Given this list of marker genes AFF1, DKK1, SNHG7, SLC16A1-AS1, ARL6IP1, TUBB4B, CALR, H3C12, SNORD50B, H2AC10P, RPS12, LDHA, IER3, MYL6, SLC3A2, LGALS1, H2BC7, VASN, PTMA, ID2-AS1, CLASP1 (NCBI Gene Id 23332, cytoplasmic linker associated protein 1), HNRNPA2B1, SLC20A1-DT, CITED2, ID4, SLC16A1, ARL15, THBS1, GEMIN6, SNHG3, STMN1, H2AC20, SNORD60, SNORA78, TOB2, KHDC4, SNHG29, MIR222HG, EEF2, H2AC6, FTH1, RPS20, MIR3190, JPT1, H4C16, MIR191, THUMPD3-AS1, SNORD43, SRSF6, EIF4A2, H3C1, RNU4ATAC, SLFN11, BRD2, POLR2A, H2BC12, DDX3X, HSPA8, RPL12, MIR3143 (NCBI Gene Id 100422934), CD44, FUS, ADAMTS4, SNORA50C, CDC25C, RPS9, MCL1, TPM2, DDIT4 (DNA damage inducible transcript 4), CEP95, SRSF3, NPM1, H2AC17, CYCS, ZBTB4, RNU11, NABP1, CYB561A3, PKM, SNHG32, PPP1R3C, H4C8 (NCBI Gene Id 8365), RPL28, GAPDH, SNORD12C, SNHG15, PMAIP1, H3C10, TUBA1B, POLR3D, SLC38A2, H2AZ1, FSCN1, TOB1, DNAJA1, ACTG1, WSB1, LINC01126, NDUFA7, ENSG00000228395, TMEM138, APTX, RND3, UBE2S, PAF1, CCNL1, SNORD54, IER5L, SRSF7, TPM1, TUBB3, H2BC10, RPL3, RPL10A, MIR5188, RPLP0, CEMIP2 (cell migration inducing hyaluronidase 2), AHNAK, ABHD5, MED29, RPS2, MRPS18B, TRIM25, MFSD11, ZFP36, TSPAN4, ENSG00000283078, LMNA, H2BC13 (NCBI Gene Id 8340), FAU, H2AZ1-DT, DALRD3, SNORD45C, CCN1, PHLDA2, RNVU1-14, UAP1, SGK1, NDUFS2, SLC1A5, SDC4, EEF1A1, PNP, SNHG19, GTF2B, PLK2, H2BC21, SNHG9, HNRNPAB, SNORA57, SPTAN1, SNORD49B, H2AC12, EIF1, H3-3B, NXF1, ID2, MRPL49, TUBA1B-AS1, TMSB10 (thymosin beta 10), RPS26, CCN2, ZFAS1, KBTBD2, RRM2 (ribonucleotide reductase regulatory subunit M2), PPP1R14B-AS1, H2BC17, MYL6B-AS1, CBX3, HEATR5A-DT, PPP1R14B, ZBTB37 (NCBI Gene Id 84614), MTRFR, MPHOSPH9, SCARNA2, STC2, GAS5, MIR4522, CALM2, SNHG1, ADAMTS1, RNU4-1, H2AC13, SETD5, CFL1, UBC, HSP90AB1, GADD45A, TOB1-AS1, VEGFA, BTG2-DT, S100A6, S100A13, GDNF, TWIST1, KLF2-DT, SNORD25, TRAF7, PA2G4, PPP1R15A, HEATR5A, SNHG5, TUBA1A, TUFT1 (NCBI Gene Id 7286), SNORD3A, TPI1 (triosephosphate isomerase 1), SNORA9 (NCBI Gene Id 677798), KLF2, HNRNPH1, CHRNA1, H2AX, H2BC16P, ATF3, RPL32, GDNF-AS1 (NCBI Gene Id 101929745), RBMX, NDUFAF3, MALAT1, H2BC4, NORAD, RPS27, FAM53C, MT1E, SLC2A3 (NCBI Gene Id 94827), WDR1, COL1A1, SNORD48, UAP1-DT (NCBI Gene Id 102724358), NUFIP2, HSP90AA1, SERPINE1, ATF4, SLC9A1, CSKMT, INTS6, DDX5, SNORD49A, H1-4, UBB, PABPC1, SLC25A3, ZFP36L2, EMP1, PRDX1, VAMP1, RCC1, PIK3R3, MAT2A, RPL13A, RPL10, S100A1, MIR3153, C11orf98, CDC25B, H1-2, H4C3, CKS2, SNHG25, H2AC7, POLR2L (RNA polymerase II, I and III subunit L), MIR320A (NCBI Gene Id 407037), RPS28, SNORD101, ALDOA, ANLN, RPLP1, HSPA1B, PRKG1-AS1, RHOB, INTS6-AS1, ACTB, ADM, SNORD26, ID1, IMPDH2, DUSP1, MKNK2, TAF4, ANO10, FLNA, JUNB, NFKBIZ, TMSB4X, SNORD104, MEPCE, SNORD27, ASF1B, C6orf62, H2AC16, PXN-AS1, RSRP1, CIRBP, LRSAM1, BTG2 (BTG anti-proliferation factor 2), ZNFX1, RABGGTB, PPP1R10, ZCWPW1, RNVU1-28, ARL4D, IER5, PPP1R15B, CALM1, DYNC1H1, SLC20A1, SRSF2, ADGRL1-AS1, TUBA1C, CERNA3, FTL (NCBI Gene Id 93315), RPSA, here is a description of the gene set: Human Gene Set: PSMB5_TARGET_GENES Genes containing one or more binding sites for (PSMB5) in their promoter regions (TSS -1000,+100 bp) as identified by GTRD version 20.06 ChIP-seq harmonization. from publication Yevshin I, Sharipov R, Kolmykov S, Kondrakhin Y, Kolpakov F (PMID 30445619) species: Homo sapiens